The following is a description of a gene set: species: Homo sapiens Studies in melanoma cells have identified MITF-M as a regulator of targets involved in extracellular matrix organization (ECM), focal adhesion (FA) and epithelial-to-mesenchymal transition (EMT). siRNA-mediated knockdown of MITF-M in the SKMel28 melanoma cell line causes morphological and cytoskeletal changes and promotes formation of aggregates on matrigel, consistent with a role for MITF-M in ECM organization and EMT. CUT-and-RUN analysis identified genes associated with ECM and FA organization that are directly bound by MITF-M and that show increased expression upon siRNA MITF-knockdown, implicating MITF-M as a repressor of these targets in melanoma cells. Of these, 42 were additionally identified as direct MITF-M targets by ChIP-seq in two independent melanoma cell line studies. MITF-M expression levels are correlated with different cellular phenotypes, with high levels corresponding to a more proliferative phenotype and low levels to a quiescent/invasive phenotype, EMT and drug resistance. Consistent with a role for MITF-M in phenotypic change, EMT-related genes such as CDH1 (E-cadherin), CDH2 (N-cadherin), SOX2 and ZEB1 were also identified as direct MITF-M targets. Reactome Pathway: Regulation of MITF-M-dependent genes involved in extracellular matrix, focal adhesion and epithelial-to-mesenchymal transition part of: MITF-M-dependent gene expression, and this is the list of marker genes: PXN, ZEB1, CDH2, PXDN, GXYLT2, SERPINE1, ITGA2, MITF, STT3B, CDH1, SOX2, EDIL3